Given this list of marker genes ETS1, OAZ2, NOTCH4, SLCO2B1, ETS2, DOCK9, ICAM2, PECAM1, ESAM, ERG, GIMAP8, SPARCL1, EPHX1, SRGN, TM4SF1, LIMS1, PPP1R12A, CAV1, MEF2C, GIMAP7, ANGPT2, TCEAL9, TGFBR2, PRSS23, MYCT1, DIPK2B (divergent protein kinase domain 2B), MGP, ARHGAP18, HLA-DRA (NCBI Gene Id 7930), FAM43A, ADCY4, UTRN, EGFL7, APLNR, TM4SF18, TINAGL1, PDGFB, FLI1, KDR, CDKN1C (cyclin dependent kinase inhibitor 1C), PLK2, MCAM, LMO2, DSTN, BEX3, PDLIM1, ITGA1, NUPR1, LIFR, CD151, CD59, TMEM88, ADGRL4, CRIM1, PTP4A3, CYYR1, ARHGAP29, MECOM, IFITM3, PALMD, RBP7, BGN, PCAT19 (prostate cancer associated transcript 19), IGFBP7, RNASE1, COX7A1, PCDH17, AP1S2, IGFBP2, NFIC, B2M, AQP1, DUSP6, LDB2, CD34, SNRK, GPIHBP1, SASH1, EPAS1, PTPRB, CAV2, DYSF, SMAD1, IFITM2, GNG11, HLA-F, ROBO4, GIMAP4, CAVIN1, PALM2AKAP2, CCL14, TJP1, AFAP1L1, MGST2, SELENOP, EMP1, LEPR, SHANK3, TNFSF10, MT1E, ABLIM1, IFI27, EFNA1, BCAM, HLA-DPB1, CTHRC1, HLA-B, CALCRL, TIMP3, ACTN4, ECSCR, EGLN1, CCN2, SELENOW, NOSTRIN, PKIG, RRAS, EHD4, ADGRF5, HSPG2, SOX18, HLA-DRB1, MYH9, ITM2A, CRIP2, JAG1 (jagged canonical Notch ligand 1), MMRN2, S1PR1, VWF, ENPP2, NFIB, ITGA6, APOD, A2M, RHOB, FLT1, HLA-C, CDH5, KCTD12, RAMP2, ITGB1, CD74, ARL4A, IGFBP4, NUAK1, CD93, EMCN, MARCKSL1 (NCBI Gene Id 65108), ELK3, TIE1, PREX2, CALM1, CSRP1, CLEC14A, GJA4, HLA-E, C1orf115, CAVIN3, EMP2, LMNA, NRGN, CLDN5, here is a description of the gene set: species: Homo sapiens The reproductive and endocrine functions of the ovary involve spatially defined interactions among specialized cell populations. Despite the ovary's importance in fertility and endocrine health, functional attributes of ovarian cells are largely uncharacterized. Here, we profiled >genes in 257 regions from the ovaries of two premenopausal donors to examine the functional units in the ovary. We also generated single-cell RNA sequencing data for 21,198 cells from three additional donors and identified four major cell types and four immune cell subtypes. Custom selection of sampling areas revealed distinct gene activities for oocytes, theca, and granulosa cells. These data contributed panels of oocyte-, theca-, and granulosa-specific genes, thus expanding the knowledge of molecular programs driving follicle development. Serial samples around oocytes and across the cortex and medulla uncovered previously unappreciated variation of hormone and extracellular matrix remodeling activities. This combined spatial and single-cell atlas serves as a resource for future studies of rare cells and pathological states in the ovary. Marker genes selected by filtering the centroid data for genes with a value > 0 for the given cell type Human Gene Set: JONES_OVARY_ENDOTHELIAL from publication Jones ASK, Hannum DF, Machlin JH, Tan A, Ma Q, Ulrich ND, Shen YC, Ciarelli M, Padmanabhan V, Marsh EE, Hammoud S, Li JZ, Shikanov A (PMID 38578993)